The following is a description of a gene set: Human Gene Set: GSE20366_EX_VIVO_VS_DEC205_CONVERSION_NAIVE_CD4_TCELL_DN Genes down-regulated in comparison of TconvLP versus DEC-Pept CD25- (see Table S1 in the paper for details). from publication Feuerer M, Hill JA, Kretschmer K, von Boehmer H, Mathis D, Benoist C (PMID 20231436) species: Homo sapiens Regulatory T (Treg) cells that express the FoxP3 transcription factor are essential for lymphoid homeostasis and immune tolerance to self. Other non-immunological functions of Treg cells, such as controlling metabolic function in adipose tissue, are also emerging. Treg cells originate primarily in the thymus, but can also be elicited from conventional T cells by in vivo exposure to low-dose antigen or homeostatic expansion, or by activation in the presence of TGFβ in vitro. Treg cells are characterized by a distinct transcriptional signature controlled in part, but not solely, by FoxP3. For a better perspective on transcriptional control in Treg cells, we compared gene expression profiles of a broad panel of Treg cells from various origins or anatomical locations. Treg cells generated by different means form different sub-phenotypes identifiable by particular combinations of transcripts, none of which fully encompass the entire Treg signature. Molecules involved in Treg effector function, chemokine receptors, and the transcription factors that control them are differentially represented in these subphenotypes. Treg cells from the gut proved dissimilar to cells elicited by exposure to TGFβ, but instead they resembled a CD103+Klrg1+ subphenotype preferentially generated in response to lymphopenia., and this is the list of marker genes: RGS16, BAMBI, CCDC88A, NRN1, RBM45, CATSPER3, PDE2A, ALCAM, CCDC122, MCOLN3, ALB, MCUB, NRP1, APOL2, DDHD1, SQOR, CFAP43, FXN, IL25, NEK5, ARMCX2, TRPS1, NTN4, SORCS1, HRH3, CCKAR, PPWD1, NOTUM, SOCS3 (suppressor of cytokine signaling 3), PPM1L, GFI1B, ANGPTL7, GJB4, DCLK1, IRF2BP2, TUBA4A, NIPAL4 (NCBI Gene Id 348938), WDR43, RIOK1, CHD1, TNFRSF13C, SAPCD1, IL1RL1, KPNA1, POLR3F, SFXN3, STK32B, SLC38A2 (NCBI Gene Id 95454), SLC4A11, IL18, MAFF, CASP3, CYP2C8, MYO1H, ACTRT3, UMOD, TP53, VCL, DUS4L, NCR1, SPIN4, CEP57, WLS (Wnt ligand secretion mediator), CCDC185 (coiled-coil domain containing 185), SLC26A10P, CPXM1, PPP1R3G, AP1S3, ENO4, MAP1LC3A, CCDC86, MLF1, MT1E, CEP83, JARID2, SFI1, LRRIQ4, SELENOS, PLEKHF2, ALOXE3, LCA5, SCG5, ZNF274, TLNRD1, GNAQ, WNT5A, KLF7, TBC1D30 (TBC1 domain family member 30), FBXW2, NR4A2, ZFP69, TNFRSF4, PROX2, PRKCA (protein kinase C alpha), MARCKSL1, H2AZ1, MYO9A, PIK3AP1, URB2, GCH1, HIC2, PDE4A, EBF3, MACROH2A2, TPD52L2, ZBTB10, CPQ, GUCA1A, PCDHB5, FAM83E, FRG1, AIPL1 (NCBI Gene Id 23746), SGK1, KDM2B, RASGRP2, DUSP10, RNF144B, NR1H4, TEX15, SLC9A2, GPR176, TUBA1A, LHX5, ELL, EID2, MYH10, RASGEF1B, AIG1, ARIH2, TAS1R2, PRPS1L1, PRNP, ATF3, STX3, FKBP11, PLAGL1, C10orf90, CD81, USP43, FCMR, ZCCHC10, SNX31, CAB39L, ABCC12, PNRC1, RGL1, MYB, LRCH4, PNPLA8, LANCL3, SAG, SLCO1B3, LRRC73, CADM1, IFITM2, FBXO16, TUSC1, ANXA1, TAGLN3, FOXP1, DNAAF1, XIST, GSPT2, KLF9, VSIG4, COL26A1, FAM184B, IKZF2, IGHG1, DUOXA1, SCARNA13, TAGAP, BRD4, TMEM87A, ZBTB21 (NCBI Gene Id 57487), DDIAS (NCBI Gene Id 84145), SEZ6L2, MAN1C1, ETF1, NFIA, EIF2AK3, VAMP3, CYSTM1, VSX1, HSD3B7, TMEM242, RAPH1 (NCBI Gene Id 80729), CST5, MFSD2B (NCBI Gene Id 388931), CBY3, TDRD9, BEX1, CDH2, IMMP2L, PIM3 (Pim-3 proto-oncogene, serine/threonine kinase), PTRHD1, CD83, ADAMTS20, RYR2 (NCBI Gene Id 6262)